The following is a description of a gene set: Genes down-regulated in comparison of control dendritic cells (DC) at 0 h versus those stimulated with Gardiquimod (TLR7 agonist) at 0.5 h. from publication Amit I, Garber M, Chevrier N, Leite AP, Donner Y, Eisenhaure T, Guttman M, Grenier JK, Li W, Zuk O, Schubert LA, Birditt B, Shay T, Goren A, Zhang X, Smith Z, Deering R, McDonald RC, Cabili M, Bernstein BE, Rinn JL, Meissner A, Root DE, Hacohen N, Regev A (PMID 19729616) Human Gene Set: GSE17721_CTRL_VS_GARDIQUIMOD_0.5H_BMDC_DN studied in species Homo sapiens mouse primary BMDCs were stimulated with tlr ligands and gene expression changes were profiled on Affymetrix arrays, and this is the list of marker genes: ARMCX4, CMC2, FAM76A, SLFN12L, ANXA8, PLCL2, PRPF40A, WBP2, STK11, ENPP1, MYMK, RPL19, GUCD1, FBLN7, PITX3, GTF3C2, AGTRAP, ASCC1, PDZK1IP1, GCLM, ACTR10, ELOC, PLA2G2D, FANCE, ZNF318, GDAP1, ZC3H12C, SDHAF1, IL7, B2M, PTPN14, STOML2, ATP2A1, SLAMF1, GNAS, MAPK7, COPZ2, IFIT1B, LAMTOR5, SOD1, RGS10, MYLK, MAGI3, LINGO1, HIVEP3, BSDC1, MEIS3, BBOX1, RABAC1, GOLT1B (golgi transport 1B), GPR3, MAGEA11, FLT4, MAZ, NDUFS2, RUFY1, SHOC2 (NCBI Gene Id 8036), ACADSB, SLC26A3, MRPL20, MAP3K12, ALDH7A1, SLC18A1, SOBP, REXO2, TSSK1B, BLOC1S4, KRT16, WASHC2A, RFXAP, DPY30, CLCN1, MYH11, RNF7, RPL30, TBCA, TMA7, RSPH1, CD82, OGFOD2, IER3, CATSPERZ, PPDPF, CLIP1, LSM3, PFKP, IDNK, SF3B4, PPP2R2D (NCBI Gene Id 55844), PFN1, TXK, KCNAB2, ROPN1, DCTN4, GJC2, CLEC1B, UCN, HAAO, CAMK2B, SMARCAL1, LARP1, CLEC6A, REPS1, MRPL2, KCMF1, FZD8 (NCBI Gene Id 8325), HSPA2, ARL3, HEXIM1, RNF25, SLC39A1, AVP, IL10RB (interleukin 10 receptor subunit beta), NR1H3, BCKDHB, F12, CPXM1, LCE3B, ASF1A, PMFBP1, MIGA2 (mitoguardin 2), EIF4EBP2, GNG11, FOXD1, LSM12, UBL7 (ubiquitin like 7), HMX3, PHYHD1, B3GNTL1, FOXG1, MARCKSL1, CSNK1D, GLIPR1, C1QL1, FRAT1, ELP2, NCOA3, SAR1B, PELO, PNPLA3, NAA38, CDCA3, PMVK (NCBI Gene Id 10654), ACTN1, SLC12A9, FMOD (fibromodulin), PA2G4, ATOSB, PRICKLE3, TBCE, TCF20, PCID2, GET4, ADGRL4, EPHX2, ZNHIT2, PTDSS1, RBX1, SH3BP5L, TNPO2, CDKN1A, H1-10, IFT22, PROCR, ACAA1, ABCD1, LIMD1, SUGT1, MSLN, TUBA1A, TMEM38A, GPR146, RNF41, DNAJB12, NDUFB11, MRPL4, SUMO3, GINM1, SPTAN1, VPS72 (NCBI Gene Id 6944), RBP3, BCL2L13, CDK5, LETM1, PHLDA1, PRELID1, VGLL1, DHH, RPIA, ARL2, EMC3, ELAPOR1, PAM, DNLZ, LENEP, PRDX1, NDUFA10, FABP5, LOXL4